Given this list of marker genes UBE2V2, TERF2IP, MAP2K3, PATL1, CCIN, EDEM1, CLN3, DARS1, SPP1, FAM210A, PER1 (NCBI Gene Id 5187), TMEM231, RAB33A, NXF1, RAB8B, COX20, LIMS3, DUSP3, TMEM248, RELT, NFKBIZ, WDR45B, TBC1D10A, EXOSC4, FCRLB, TBC1D22A, NR4A1, IFNGR2, VDAC2, TNFRSF8, RAB21, INTS13, NEPRO, SGF29, ASCC1, CARD19, PSMA6, RNF181 (ring finger protein 181), CHMP4B, GZF1, SERTAD2, PKM, GUK1, TSPAN14, PDK1, MYNN, SBF2, MAPK1IP1L, PRICKLE3 (prickle planar cell polarity protein 3), ENSG00000291149, CFDP1, TBC1D2, C4orf3 (chromosome 4 open reading frame 3), ESCO1, RELA, NFKBIE, ZNF395, JMJD6, ARHGDIA, THAP8, NOD2, PHACTR1, HPCAL1, GPR12, ETV5, RHBDF2, GYS1, NINJ1, RIMKLA, KMT2E, AMPD3, ZBTB25, PIGA, TMEM91, YEATS2, EPOP, TNFRSF1B, P4HB, VGLL4, LSM12, NFXL1, BCL2A1, AKAP10, MFSD12, LONP1, TCAF2, SLC31A1, BNIP3L, C17orf49, SNX20, SQOR, HK2, GPAT4, ICAM1 (intercellular adhesion molecule 1), GPI, SERTAD3, ZNF292, G0S2, SH3D21, PPP1R14B, PDXK, PARP6, OXSR1, DDIT3, FKBP15, CNOT1, RTL8C, UGP2, OPA3, DERL1, TAS2R1, DDX50, NXT1, SRSF3, MXI1 (NCBI Gene Id 4601), SLC3A2, TNFAIP8, PIK3CB, OSM, ALOX12B, NARF, WDR64, SAP30, UFSP2, VEGFB, VPS18, MORF4L2, SNAPC1, PIK3IP1, H2BC13, KCTD11, ALDOA, DOCK3, SERPINE1, LRRC73, ELF4, MRGBP, RLF, PHF1, RNMT, FUT11, PHF21A (PHD finger protein 21A), RBM8A, ORC1, CRTC2, CYSTM1, TNIP1, MFAP1, HPS5, USP28, LGALS8, CA11, FAM162A, IL18BP, SLC25A26, ZC3H12A, PKD2, PHC2, ALKBH5, MEA1 (male-enhanced antigen 1), OXSM, SLC43A3, ATG9A, MAP2K1, GRINA, FKBP2, ERO1A, NTMT1, ADAM17, USP37, CFAP36, KDM4B, B4GALT5, ENO1, MTFP1, DDX41, EIF4A3, RNF227, MGARP, FFAR3, IL4I1, GRAMD1A, AK2, CSRNP1, TPI1, ZNF12, KDM4C, ZNF654, SAMTOR, CEBPB, TNFAIP3, PPP1R15A, CYC1, GNA15 (G protein subunit alpha 15), WDR54, FAM13A (family with sequence similarity 13 member A), NUP58, KDM3A, here is a description of the gene set: from publication Schwartz JT, Bandyopadhyay S, Kobayashi SD, McCracken J, Whitney AR, Deleo FR, Allen LA (PMID 22986450) Genes down-regulated in comparison of control polymorphonuclear leukocytes (PMN) at 12 h versus PMN treated with F. tularensis vaccine at 12 h. Human Gene Set: GSE37416_CTRL_VS_12H_F_TULARENSIS_LVS_NEUTROPHIL_DN We demonstrated recently that both constitutive and FAS-triggered apoptosis of human neutrophils are profoundly impaired by Francisella tularensis, but how this is achieved is largely unknown. To test the hypothesis that changes in neutrophil gene expression contribute to this phenotype, we used human oligonucleotide microarrays to identify differentially regulated genes in cells infected with F. tularensis strain LVS compared with uninfected controls. In order to examine the effect of F. tularensis on the neutrophil transcriptome, we performed microarray expression analysis on human neutrophils treated with F. tularensis subsp. holarctica live vaccine strain (LVS). studied in species Homo sapiens